The following is a description of a gene set: The process in which genetic material, in the form of chromosomes, is organized into specific structures and then physically separated and apportioned to two or more sets during M phase of the meiotic cell cycle. studied in species Homo sapiens Human Gene Set: GOBP_MEIOTIC_CHROMOSOME_SEGREGATION, and this is the list of marker genes: KNL1, AURKA, C14orf39, MAJIN, TRIP13, SYCP2, SYCE1L, MAEL, MRE11, KASH5, CCNE2, ZWINT, FMN2, DDB1, SMC4, FBXO5, PTTG1, PTTG3P, ANKRD31, CENPC, AGO4, ZCWPW1, STAG3, MCMDC2, BRIP1, MSH4, MEIOB, SPDYA, M1AP (NCBI Gene Id 130951), TEX12, CCNB2, NDC80, SEPTIN1, IHO1, SIRT7, CCNB1IP1, GOLGA2, MLH3 (mutL homolog 3), MLH1, TTK, SKA3, SHOC1, NCAPH, MND1, SYCE3, ASPM, NUF2, SPO11, SPATA22, TUBB8, PTTG2, UBE2B, TEX15, SYCE2, NCAPH2, MEIKIN, DMC1, TEX11, RNF212, PLK1, TERB1, SMC2, TERF1, C9orf78 (NCBI Gene Id 51759), FANCD2 (NCBI Gene Id 2177), SKA2 (NCBI Gene Id 348235), C1orf146, SYCE1, ESPL1, WASHC5, MEI4, RNF212B, MAPK15, MEIOC, CCNE1, MOS, PTEN, ATM, SKA1, ACTR2, SGO1, HORMAD1 (HORMA domain containing 1), PPP2R1A, MSH5, REC8 (REC8 meiotic recombination protein), PRDM9, SYCP1, DCAF13, PSMC3IP, P3H4, CHFR, ACTR3, SUN1, EHMT2, BAG6, NDC1, TERB2 (telomere repeat binding bouquet formation protein 2)